Given this list of marker genes Gfus, Thy1, Ccl28, Ninj1, Cdh13, Hrg, Pcsk5, Dicer1, Tsc1, Csf1, Fermt1, Utrn, Abl1, Myoc (myocilin), Ppm1f, Wnt4, Ccl21a, Rock1, Dmd, Fmn1, Ccl21d, Disc1, Rin2, Ccl21b, Poldip2, Itgb1bp1, Sec1, Plpp3, Jup, Itgb3, Lims1, Rras, Prkcz, Vegfa, Enpp2, Ilk, Rac1, Dag1, Skap1, Cfl1, Gsk3b, Myh9, Ccl21e, Ptprj, Trem1, Cd36, S100a10, Ptpn11, Nrp1, Iqgap1, Ccl25, Cib1, Sdc4, Col16a1, Epha1, Fut1, Kdr, Cd3e, Map4k4, Ptk2b, Fermt2, Tek, Smad3, Plekha2, Ccl21f, Cripto, Emp2, Cdk6, Epb41l5, Efemp2, here is a description of the gene set: Mouse Gene Set: GOBP_POSITIVE_REGULATION_OF_CELL_MATRIX_ADHESION studied in species Mus musculus Any process that activates or increases the rate or extent of cell adhesion to an extracellular matrix.